The following is a description of a gene set: Human Gene Set: HP_INVERTED_NIPPLES studied in species Homo sapiens The presence of nipples that instead of pointing outward are retracted inwards. Inverted nipples, and this is the list of marker genes: ACOX1, WAC, CACNA1C, PMM2 (NCBI Gene Id 5373), PEX3, DEF6, MGAT2, RTL1, SOX6, MEG3, HNRNPK, C18orf32, ALG11 (ALG11 alpha-1,2-mannosyltransferase), MAN1B1, RERE (arginine-glutamic acid dipeptide repeats), ALG3, WASF1, ALG8, TRAF7, EIF4A2, ATN1, NFIX, ALG9, RNU4-2, EBF3, ALG12, LBR, SRD5A3, TWIST2, JARID2, NSUN2, SET, DPM1, SLC35A2, EZH2, TCF20, DPAGT1, RFT1, INTU, STT3A, ALG2, KMT2B, KAT6A, DLK1, TBX3, PIGT (NCBI Gene Id 94004), SLC4A10, BICRA, B4GALT1, SLC25A46, COG7